The following is a description of a gene set: Human Gene Set: GOBP_REGULATION_OF_LEUKOCYTE_ADHESION_TO_VASCULAR_ENDOTHELIAL_CELL Any process that modulates the frequency, rate or extent of leukocyte adhesion to vascular endothelial cell. studied in species Homo sapiens, and this is the list of marker genes: CXCL12, ST3GAL4, TRAF6, FUT9, MIR125A, MIR141, MIR31, MIRLET7E, SELE, CCL28, MIR146A, FUT4 (NCBI Gene Id 2526), ETS1, GCNT1, RELA, MIR92A1, NFAT5, MIR221, MIR222, MIR21, MDK, ITGA4, TNF, CCL21, ALOX5 (NCBI Gene Id 240), ITGB2, ELANE, CHST4, CCR2, CHST2, IL6, ZDHHC21, IRAK1, KLF4 (KLF transcription factor 4), MIRLET7G, RHOA, SELP, CCL25, FUT7